The following is a description of a gene set: Genes containing one or more binding sites for (Dnmt1) in their promoter regions (TSS -1000,+100 bp) as identified by GTRD version 20.06 ChIP-seq harmonization. studied in species Mus musculus Mouse Gene Set: DNMT1_TARGET_GENES from publication Yevshin I, Sharipov R, Kolmykov S, Kondrakhin Y, Kolpakov F (PMID 30445619), and this is the list of marker genes: Klk5, Gal3st2b, Mir7066, Tmem235, St3gal3, mt-Nd4, Gm36535, Arhgap11a, Mapk8, Gm15759, Arhgap28, Etfb, mt-Tq, Gm26015, Speg, Gm24536, Gm13215, Gm21978, Slc39a3, Camta2, mt-Tg, Gm24254 (predicted gene, 24254), Arhgef40, Tmem59l, Pdxk-ps, Rap1gap, Def8, Nphs1, Samd4, Cpne1, Gm15564, Gm15503 (predicted gene 15503), Iftap, Gm43391, Ttc22, 3110070M22Rik, Plch2, Kalrn, Gm23980, Jaml, mt-Tr (mitochondrially encoded tRNA arginine), Gm26413, Tbcb, Akap9, Vmn1r198, Atp6v0a2, 9030204H09Rik, Gm5190, Echdc3, Dpf1, Gna15, Gm19461, Ptpn23, Sfi1, Mapk13, A930005G22Rik, Or4k40, Mff, Gm3940, A730098A19Rik, Serpinb6e, Tkt, Cox7a2l, Obsl1, Rag1, Gm21399, Frmd4a, Speer4c2, Stxbp2, Vsig10l, Arid1a, Gm26007, Sucla2, Echdc2, Atp2b4, Or6c8, Pkd1l2, Nrxn2, Mlxipl, Gm11399 (predicted gene 11399), Inpp4a, Arfgef1, Gpr183, Cabp2, Gm15217 (predicted gene 15217), Tppp3, Galnt15, Gm6652 (predicted gene 6652), Tmem134, Ampd1, Mcoln1, Gm29083, Gm26747, Gm6136, Smok2b, mt-Nd1, Duxf1, Col9a2, Oas3, Niban3, Mtmr10, Zmat4, Erbb2, Gm2310, Cd84, mt-Tl1, mt-Nd3, Marchf1 (membrane associated ring-CH-type finger 1), Rab7b, Abo (ABO, alpha 1-3-N-acetylgalactosaminyltransferase and alpha 1-3-galactosyltransferase), Gm12853, Gm7003, Tmem44, Gng7, Golga2, Cela2a, Gm16142, Scml4, Rnf43, Camsap3, Or6c6c, Gm9951, Gm23879, Gm8357, Gm16149, Itsn1, Or2ab1, Bglap3, Tanc1, Gigyf2, Wscd2, Serpinb2, Gm29926, Tbata, Slc25a40, Gm23645, Gm3985, Coq8b, Or4d1, mt-Nd4l, mt-Cytb, Gm7676, Gm2053, Col11a2, Oaz1, Kcnj15, Vmn2r-ps111, Rsph14, Capn2, Spaca3, mt-Tw, Mbd6, Fau-ps2, Pth2, Gabbr1, Smok2a, Gimap9, Atp6v1c2, Col24a1, Lrrc8d, Srrm3, Mob4, Rab20, Sema3f, Dhodh, Ace2, Slc11a2, Esr1, Ap3m2, Lig1, Gm16477, 9130230L23Rik, Fndc3a, Usp37, Fhip2b, Mir1839, Smim23, Gm21847, Tsc22d1, Tspan3, Gm22863